Given this list of marker genes AHNAK2, SFN, ABCB1, TBX3, SQSTM1, DNER, CLDN4 (NCBI Gene Id 1364), CRYAB, TEX19, COL7A1, CLN3, S100A13, CCNT1, MYL11, ENPP5, CXCL16, S100A1, PTER, SLC39A4, PATL2, TACSTD2, MROH1, AQP3, STMN3, PXDC1, ITGB4, BBS7, ABHD14B (abhydrolase domain containing 14B), EEIG1, C15orf48, FHL2, CAPNS1, CHRNB1, HSD3B7, PGC, ACADVL, KRT14, MVP, BBS2, GPX2, CLTB, BMP1, CD68, ANXA5 (NCBI Gene Id 308), SNHG11, KRT18, HTRA1, WDR45, PROS1, GALM, ARL4C, here is a description of the gene set: from publication Kohoutek J, Li Q, Blazek D, Luo Z, Jiang H, Peterlin BM (PMID 19364821) The positive transcription elongation factor b (P-TEFb) is essential for the elongation of transcription and cotranscriptional processing by RNA polymerase II. In mammals, it contains predominantly the C-type cyclin cyclin T1 (CycT1) or CycT2 and cyclin-dependent kinase 9 (Cdk9). To determine if these cyclins have redundant functions or affect distinct sets of genes, we genetically inactivated the CycT2 gene (Ccnt2) using the beta-galactosidase-neomycin gene (beta-geo) gene trap technology in the mouse. Visualizing beta-galactosidase during mouse embryogenesis revealed that CycT2 is expressed abundantly during embryogenesis and throughout the organism in the adult. This finding was reflected in the expression of CycT2 in all adult tissues and organs. However, despite numerous matings of heterozygous mice, we observed no CycT2(-/-) embryos, pups, or adult mice. This early lethality could have resulted from decreased expression of critical genes, which were revealed by short interfering RNAs against CycT2 in embryonic stem cells. Thus, CycT1 and CycT2 are not redundant, and these different P-TEFb complexes regulate subsets of distinct genes that are important for embryonic development. Genes down-regulated in E14 ES (embryonic stem) cells upon knockdown of CYCT1 by RNAi. studied in species Mus musculus Human Gene Set: KOHOUTEK_CCNT1_TARGETS